Given this list of marker genes KRTCAP3, GATD3, GPN1, CPT1A, PLCH2, IGSF10, SEC14L1, NAV1, CAMK2G, SCN8A, STIMATE (STIM activating enhancer), ALCAM, SLC7A1, SS18, GRID2 (glutamate ionotropic receptor delta type subunit 2), SEPTIN3, here is a description of the gene set: studied in species Homo sapiens from publication Chen Y, Wang X (PMID 31504780) Genes predicted to be targets of miRBase v22 microRNA hsa-miR-604 in miRDB v6.0 with MirTarget v4 prediction scores > 80 (high confidence targets). Human Gene Set: MIR604